Given this list of marker genes Ctcf, Brd2, Rad21, Pcbp2, Nipbl, here is a description of the gene set: Mouse Gene Set: GOBP_CHROMATIN_LOOPING A chromatin organization process that starts with the loading of an extrusion motor (by an SMC family complex) onto the chromatin, followed by chromatin extrusion that stops at loop anchoring sites on the chromosome. studied in species Mus musculus